Given this list of marker genes PES1, GPRASP3, ARHGEF6, IRGQ, SAMHD1, EPHB6, BASP1, NR4A3, SH2D2A, ETV5, PLD6, RBMS2, LZIC, JARID2, MYL10, ZMYM4, CCR9, TANC2, BACH1, CCDC28B, FPGS, TOX, HMGN3 (NCBI Gene Id 9324), IQCG, TRIB1, UBE4B, DAPK1, SH2D1A, ARMCX1, TGIF2, POLB, CDK6, PRMT2, PHC1, ZNF821, F13A1, MRTFB, TMCC3, HNRNPA1, GREB1 (growth regulating estrogen receptor binding 1), RPL7L1, EGR2, GNAQ, PDCD5, TMEM218, PPP6R1, FIZ1 (FLT3 interacting zinc finger 1), TCEAL8, DNTT, MMP9, CCT3, PLXDC2, RAG1, WDFY2, ALAD, GSK3B, MAPK7, CUL7, PI4K2B (NCBI Gene Id 55300), ANGPTL2, SPIN1, AS3MT, SMIM13, ITGA8, PRR3, SLC27A1, CHDH, ZNF219, MCCC1, TRIO, TP53BP1, MCU, ARF1, SH3BP2, PLOD2, GPRASP1, CAND2, SMAD3, ST3GAL2, HLA-DMB, ZNF410, BUD23, TRAF4, L3MBTL3, DUSP12, ZNF22, SLC35A1, ATF4, PADI3, TMEM11, UNC119, EIF2B3, KDM5B, BCOR, RAB8B (RAB8B, member RAS oncogene family), MAP2K2, TACC2, PTPRF, TBC1D19, SHF, GK5, ZNF32, SLC25A17, ITGAL, ARMCX6, SLC25A38, MIDN, CRY1, SLC16A10, SLC12A5, PIK3R3, KCNMB4, COL1A2, FMNL3, NSFL1C, NMNAT1, RRAD, LCMT1, GATA3, RORA, ACOT7, GOLM2, LXN, TSC22D1, ZNF467, CHL1, MPHOSPH6, HS2ST1, AFDN, ZNF799 (NCBI Gene Id 90576), HIVEP3, IMP4, MRPS27, PIPOX, MEA1, STK40, ZFTA, BCL2L11, CACNG4, LDHB, CHST2, PRMT5, EGR1, LLGL1, ZNHIT6, GPD2, TM6SF1, PAFAH1B3, PLXND1, ATXN1, MEX3A, CCR4, CSK, RAP1A, HACD1, RALBP1, USP22, ZBED5, SLC39A14, NABP1, PDXK, CSNK1E, GPR174, CRYZ, LMO4 (LIM domain only 4), GALC, RELB, BCR, PTOV1, KLHL25, XYLT2, ALDH7A1, TIAM1, CAMK4, DAP3, EDARADD, SLAMF1, DIABLO, FHIT, ICAM1, GTDC1, ERF, NR4A1, BLOC1S5, SLC37A2, SYTL2, TOX2, LHFPL6, ARMCX2, PLIN2, ADAM11, PDRG1, CLPB, B9D1, RPS19BP1 (ribosomal protein S19 binding protein 1), TFRC, BUB3, GPRASP2, ZNF212, here is a description of the gene set: Human Gene Set: GSE40443_INDUCED_VS_TOTAL_TREG_UP species: Homo sapiens from publication Weiss JM, Bilate AM, Gobert M, Ding Y, Curotto de Lafaille MA, Parkhurst CN, Xiong H, Dolpady J, Frey AB, Ruocco MG, Yang Y, Floess S, Huehn J, Oh S, Li MO, Niec RE, Rudensky AY, Dustin ML, Littman DR, Lafaille JJ (PMID 22966001) Genes up-regulated in T reg: induced versus total. iTreg cells from Tbmc mLN mice treated with one week of 1% Oral Ova were compared to Total Treg from WT mice.